Given this list of marker genes KRIT1, RNF43, LZTR1, COQ6, SMARCB1 (SWI/SNF related, matrix associated, actin dependent regulator of chromatin, subfamily b, member 1), NF1, PIK3CA, PDCD10, MBD4, NF2, PRKAR1A, PDE11A, SPRED1, HRAS, KARS1, CCM2, here is a description of the gene set: Human Gene Set: HP_SCHWANNOMA Schwannoma studied in species Homo sapiens A benign nerve sheath tumor composed of Schwann cells.